Given this list of marker genes Apol10b, Apol8, Ambp, Calr, Lrp1, Sparc, Alb, Apol9a, Cd163, Masp1, Apoe, Cd36, Hsp90b1, Colec11, Igll1, Apol9b, Apol11b, Hbb-bt, Apob, Apol7e, Apol7a, Hpx, Apol7b (NCBI Gene Id 278679), Apol10a, Apoa1, Stab2, Hp, Msr1, Hmgb1, Prdx1, here is a description of the gene set: electronically inferred by orthology from the curated human pathway studied in species Mus musculus This event has been computationally inferred from an event that has been demonstrated in another species.<p>The inference is based on the homology mapping from PANTHER. Briefly, reactions for which all involved PhysicalEntities (in input, output and catalyst) have a mapped orthologue/paralogue (for complexes at least 75% of components must have a mapping) are inferred to the other species. part of: Vesicle-mediated transport Reactome Pathway: Binding and Uptake of Ligands by Scavenger Receptors